Given this list of marker genes CD59, IGF2R, FAM168A, SOCS6, BAZ2A, SLF2, KIAA1549L, SLC35F1, GDF5, WNT1, ATP12A, CCDC149, ZDHHC6, FAM53B, CIT, RACGAP1, CD84, PKD2L2, CPSF7, TBR1, GSDMC, TMCO1, MIER1, LEPROT, AMOTL2, RTL5, KAT7, ANKUB1, TROAP, HBP1, TOP1, RIMBP2, IGSF5 (NCBI Gene Id 54046), KLHL24, SCAF4, POU3F3, FOXJ2, KANK2, CEP120, VWC2, CCDC178, ENDOD1, BRPF3, HPSE, UBE2QL1, ARHGEF39, ZBTB39, EYA4, PRKRA, GRSF1, ABRAXAS1, ING3, KRT40, GPR65, SNPH (NCBI Gene Id 9751), FMNL3, GABRA6, GFRA1, RNASE2, NOL4L, LUZP1, SEMA7A, SLAMF7, MBP, CCDC127, FAM167B, ZNF280D, ZNF99, SH3TC2, MAP7D3, SV2A, VRK3, SLC34A1, BCAT1, ZNF652, NRN1, S1PR1, ESYT1, ADCYAP1R1, GABRB2, NR6A1, IL13RA1, ENSG00000187186, EXOC8, IPO5, GRIN2A, CNGA3, BLMH, here is a description of the gene set: species: Homo sapiens Human Gene Set: MIR4689 Genes predicted to be targets of miRBase v22 microRNA hsa-miR-4689 in miRDB v6.0 with MirTarget v4 prediction scores > 80 (high confidence targets). from publication Chen Y, Wang X (PMID 31504780)